The following is a description of a gene set: Fatty acid transporters Human Gene Set: WP_FATTY_ACID_TRANSPORTERS studied in species Homo sapiens, and this is the list of marker genes: ACSL3, ACSL4, FABP2, FABP6, FABP7, FABP5, ACSBG1 (acyl-CoA synthetase bubblegum family member 1), CD36, DBI, ACSL6, ACSL5, FABP3, SLC27A4, FABP4, FABP9, FABP1, ACSBG2, ACSL1